The following is a description of a gene set: mouse primary BMDCs were stimulated with tlr ligands and gene expression changes were profiled on Affymetrix arrays Genes down-regulated in comparison of dendritic cells (DC) stimulated with poly(I:C) (TLR3 agonist) at 0.5 h versus those stimulated at 8 h. from publication Amit I, Garber M, Chevrier N, Leite AP, Donner Y, Eisenhaure T, Guttman M, Grenier JK, Li W, Zuk O, Schubert LA, Birditt B, Shay T, Goren A, Zhang X, Smith Z, Deering R, McDonald RC, Cabili M, Bernstein BE, Rinn JL, Meissner A, Root DE, Hacohen N, Regev A (PMID 19729616) species: Homo sapiens Human Gene Set: GSE17721_0.5H_VS_4H_POLYIC_BMDC_DN, and this is the list of marker genes: TAL1, CNOT2, GATAD2A, POLR2B, BLOC1S6, GOSR1, TSC22D1, MS4A6A, PON3, TDRD7, H2AC25, ASPRV1, TNFSF9, ADAP2, CXCL9, PEX11B, PHETA2, MLLT10, ARHGAP6, SERTAD1 (SERTA domain containing 1), STARD5 (StAR related lipid transfer domain containing 5), VCAN, ZNF436, ORC1, SEC13, MYO1E, RAB33B, LMBRD1, NR3C1, ATP6V0A2, SQSTM1, TTI2, MAN1A2, ANXA7, HOOK2, NFKBIA, GFPT1, PLEKHA3, VRK2, MITF, CLDND1, WASHC3 (WASH complex subunit 3), ZNF106, PACS1, FDPS, GLCCI1, UBE2N, DLGAP4, USP8, KDR, SOS1, NKG7, PTGR3, XPO4, GCC1, UBE2E3, OSBPL11, NUB1, TRIM34, GCH1, CCDC127, CCNT2, DHX58, DOP1B (NCBI Gene Id 9980), DCLRE1A, C6orf62, ST3GAL5, CYBB, PEX13, RPE, TMEM266, MTF2, PSMA4 (proteasome 20S subunit alpha 4), KBTBD2, IGFBP2, PPP1R15A, CUL4B, CDKN1A, ARID4B, DRAM2, CHMP3, FABP3, PDCL, PDE6B, HELZ2, TULP4 (TUB like protein 4), RPS6KA2, VPS72 (vacuolar protein sorting 72 homolog), PLK2, CARHSP1 (calcium regulated heat stable protein 1), CLYBL, STAU1, PEX26, ATF3 (NCBI Gene Id 467), CHIC2, STAM, IRF2, SYNJ2BP, SEC24D, RAB31 (RAB31, member RAS oncogene family), NIPA2, NDUFA7, CROT, DUSP16, FBXW7, PCNA, PTPRO, ABR, CST7, XRN2, CDC42SE1, GBP2, ATE1, SMOX, SOCS6, N4BP1, STX18, MYT1, PLPP7, OAS2, CPSF2, PLPP3, PDK3, SMC5, ZDHHC5, BFAR, TECR, ANKRD26, UBAP1, CKAP5, CCNI, ADAT1, PDLIM5, RSAD2, IREB2, ZDHHC20, FBXW11, USP25, NAMPT, MBL2, LZTFL1, SPTLC2, RNF34, PRPF3, HIPK3, SSTR1, CCL2, UBXN8, GAL3ST1, SRXN1, ENDOD1, GSR, DBR1, FXR2, WASHC4, IL6ST, RBM43, NPY1R, PLEKHA2, ITGA4, PPP2R5A, GAST, PARP4, RALGDS, ETF1, BNIP2, USO1, KLRK1, PDE7A, OSTF1, PCNX1, MSN, CSF1, MYO1D, ZNFX1, CCDC6, P2RY14, NFKB1, ATAD2B, NDP, USP11, TFDP1, KEAP1, MARK4, RTCA, ASH2L, NEU3, KRCC1, NET1, C9orf72, SCX, MOSPD2, EFR3A, BAZ2A, HAX1, KHDC4, PLEKHN1, TMEM242, CD38, TIAM1